The following is a description of a gene set: Retrograde transport at the Trans-Golgi-Network Mouse Gene Set: REACTOME_RETROGRADE_TRANSPORT_AT_THE_TRANS_GOLGI_NETWORK species: Mus musculus, and this is the list of marker genes: Sys1, Napg, Vps54, Tgoln1, Scoc, Rgp1, Arl1, M6pr, Rab9, Napa, Usp6nl, Ric1, Cog1, Golga4, Vps53, Cog5 (component of oligomeric golgi complex 5), Rab9b, Golga1, Arfip2 (ADP-ribosylation factor interacting protein 2), Igf2r, Cog6, Rab6a, Rabepk, Nsf, Arfrp1, Rhobtb3, Stx6, Cog2, Gcc2, Vamp4, Gcc1, Cog8, Cog3, Stx16, Vps52, Vti1a, Napb, Rab6b, Cog4, Cog7, Vamp3, Tmf1, Plin3, Vps51, Rab43